The following is a description of a gene set: The series of molecular signals mediated by a sphingolipid. Mouse Gene Set: GOBP_SPHINGOLIPID_MEDIATED_SIGNALING_PATHWAY studied in species Mus musculus, and this is the list of marker genes: Sphk1, S1pr2, S1pr1, S1pr3, S1pr4, Pik3cb, S1pr5, Plpp3, Gpr6, Ezr, Pik3cg, Sphk2, Rac1, Mfsd2b, Smpd3, Spns2, Akt1, Klf14